Given this list of marker genes ABCG4, TMEM218, MAPK13, TRIM66 (tripartite motif containing 66), NOVA2, DLG2, LCOR (NCBI Gene Id 93376), SLC25A15, ARFIP2, BCAT1, SNX19, ARID1A, EIF2AK1, NPHS2, PCDHA4, COCH, CNTD1, MYBL1, AKR1C2, PCDH9 (protocadherin 9), SYN1, HIPK2, ATXN1, SPIN3, SHISAL1, SETD5, TMEM165, ADGRB1, SLC25A28, SARNP, ADH4, FKTN, EPPK1, CEP104, NDUFA10, MAGI1, ANKS4B, ADAM22, GINS1, TPMT, CGN, CPNE6, ADRA1A, HCN4, CNTLN, LPCAT3, POPDC2, PXT1, KIAA1328, GLYAT, NRSN1, BTN2A2, MON1B, OPCML, CCND2, ADAMTS17, RGS8, GPX3, SLC17A7, FJX1, ZNF473, CD84, MAP3K20, RFLNA, PRTG, SPATA2, INTS6 (NCBI Gene Id 26512), SIX2, KLK5, PCDHA10, TTBK1, RBM15B, NMNAT2, TSPAN18, ARPC4, UBE2H, ZFP1, ELOVL4 (NCBI Gene Id 94678), B9D1, ZNF444, PATZ1, ARMC9, ZNF586, FAM135B, ATAT1, PRKAB2, RAB35, SORT1, FAM151B, RALGAPB, ARL3, GSTA4, MLLT11, THRA, C12orf43, RAE1, HDX, FMN1, ABCA3, ATP6V1F, GATAD1 (GATA zinc finger domain containing 1), CENPO, STRN, SLC17A2, EYA3, TRIP12, PCDHA7, NFATC2, MSI1, CDC42, USB1, ANKFY1, DCX, COMMD2, MYADM, CNTNAP5, YIPF1, LINC03043, PAK6, ANKRD45, MAU2, PNP, IL2RA, CHMP7, GJA1, ASTN2, KIDINS220 (kinase D interacting substrate 220), CLCN6, PCDHA11, ZNF557, PTGDR2, TRIM58, PCDHA3, UMPS, LARP1, MEX3A, NHLRC2, PHF21A, PHETA2 (PH domain containing endocytic trafficking adaptor 2), PARP9, HDAC5, SUMF2, ATP2A2, KAT6A, CSRNP2, FBXO41, NFATC1, RNASEH2B, CXCL9, PTPN13, C9orf57, LRIT1 (leucine rich repeat, Ig-like and transmembrane domains 1), CARF, MOCS2, DCTN3, SIX3, KDM3B (NCBI Gene Id 51780), EXD2, USP3, PHLDB1, SDF2, PBX2, RORA, TNFSF12-TNFSF13, HIC2, FBXL20, FOXP4, BEND4, SLC8A1 (NCBI Gene Id 6546), AR, PCDHA6, PALM2AKAP2, UBXN10, TOX3 (TOX high mobility group box family member 3), SPTBN1, CELF2, ELMO1, RIC8B, GEMIN7, ZNF662, UBE2D4, CASP14, CLMN, UBE2W, ZNF2, CNOT9, ITM2C, PAK3, VGLL3, MXRA5, SREBF2, B3GAT1, NETO1, NAA40, RAB3D (NCBI Gene Id 9545), CTC1, TFDP1, MRPS21, IPCEF1, LRRC27, DOCK3, TRGC1, SNX30, PGLYRP4, LYN, SSTR2 (somatostatin receptor 2), LHX2, SNAP25, TBC1D30, GPR84, ADGRL1, SIPA1L1, CHRNB4, ZNF469, ORC5, ATP1A3, MAB21L2, PTPA, PREPL, ARMC8, CDH4, ENC1, CCDC97, TBC1D5, SORL1, PAX5, FANCA, AGPAT3, GCKR, CREBRF, XKR5, PTGR3 (prostaglandin reductase 3), BTLA, ELOVL2, RHOA, NR1D1, MTHFS, TAP2, SRGAP2, CA10, FZD4, CFAP44, ERCC6, WDCP, FAM76A, CACNG4, PCDHA12, FBXO48, DTNA, SFT2D3, ZC3H11C, PCDHA1, AFAP1L2, CCNL2, RNF180, HP1BP3, JAGN1, RNF20, ARF3, GSTT2B, CTDNEP1, KSR2, TNFSF13, TTC3, PCDHAC1, RNASE9, SOX5, TRAF3, TANC2, TEAD1, EFTUD2, PCDHA9 (protocadherin alpha 9), MTCL2, FBXL17, LIFR (NCBI Gene Id 3977, LIF receptor subunit alpha), XYLT1, ZNF665, ZC3H11A, PPP6C, ST20-MTHFS, PLAGL2, SSX4B, FAIM2, RHOT1, ACACB, GPNMB, OTUB2, PDK3, ZNF37A, CDYL2, LRRFIP1, FAM234B, PRR23A, LDLR (NCBI Gene Id 3949), PLA2G2F, GNB3, NPL, KLHL29, SYNM, YWHAG, RAB30, GJA5, BTG2, EFCAB2, PARP11, GRM6, PM20D1, NFATC3, APH1A, BTBD9, RSU1, ANKRD34A, KLF7, GRIN2B, TMEM139, FNDC9, HOPX, EIF4EBP2, ZSCAN22, SPTB, C1orf21, NPNT, EPB41L1, PCDH10, MNT, KCNK9, KPRP, FAM222B, UBR2, TPD52L1, ZCCHC12, HOOK3, MCHR1, PRR5L, PRKAR2A, TBC1D19, CDH23, SPATS2, GPR26 (G protein-coupled receptor 26), PCDHA2, SLC16A2, SBK1, IP6K1, WNT1, PMF1, CNTN2, PCDHA8, RCC1L, PCLO, SSX4, DEFA5, EMC10 (ER membrane protein complex subunit 10), XYLB, ENAH, SAR1A, CLEC4M, DDX18, CAMK2D (NCBI Gene Id 817), PLEKHA5, ABCG1, PPME1, MIER1, IKZF4, HK2, LRRC32, PPP6R1, PCDHAC2, TMOD2, PIM1, CACNB1, PCP4, SET, USPL1, ZBTB5, SLC25A53, MRPL34, ITGB3, TMEM214, NBN, EPHB2, SSX1, SETBP1, STX6, SLC30A3, LZTFL1, SEL1L3, QSOX1 (NCBI Gene Id 5768), TCP1, METTL25B, TUBGCP3, RDX, EXOC6B, MAT2A, HIF1AN, SIX1, OPRM1, MS4A3, FIGNL2, SCD, GPX6, USP49, FCER2, TRPM3, KCNJ5, FANCD2OS, SMCO4, VCF1, ZNF236, TSHR, PCDHA5, RAB15, NEK6, TCF12, TMEM182, PCDHA13, SOX13 (NCBI Gene Id 9580), RIMOC1, BRPF3, CSMD2, CAPZB, ZNF687, AGO1, SLC13A3, SF1, PPP1R3B, RASEF, FCRL3, BASP1, SSX7, SIGLEC1, ULK4, SH3BP2, TAF5L, TTC28, SGMS1, SMG7, RERE, AKAP6, MECP2, ETV3L, INO80D, PRSS16, GEMIN8, CARD18, NCAN (neurocan), WNT9B, GTF3C4, CEP15, MS4A2, CD300LD-AS1, ISG20, NOTCH2, ANKRD17, DDX41, KANK2, HCCS, TMEM150C, FOXN4, VANGL1, ZNF704, KCNN3 (NCBI Gene Id 95947), DYNLL2, URM1, SLC7A1, FAM168A, LAMP5, BSN (bassoon presynaptic cytomatrix protein), CKAP2, FAM163B (NCBI Gene Id 649590), DPEP2NB, PITPNA, IDE (NCBI Gene Id 3416), GNRHR, CD209, EPB41L4A, here is a description of the gene set: Genes predicted to be targets of miRBase v22 microRNA hsa-miR-4306 in miRDB v6.0 with MirTarget v4 prediction scores > 80 (high confidence targets). from publication Chen Y, Wang X (PMID 31504780) studied in species Homo sapiens Human Gene Set: MIR4306